Given this list of marker genes TMEM41A, METTL2B, FAM120A, TUBGCP5, SETD9, BAG5, GART, BCOR, SOS1 (SOS Ras/Rac guanine nucleotide exchange factor 1), STRADB, PLXNC1, RGPD4-AS1, TLR2, POGLUT2 (protein O-glucosyltransferase 2), PBK, GAPDHP62, PARP9, LAP3, UTP18, TAF9B, SPTLC2, IQCC, VAPA, WDR7, NBPF10, LONRF2, CD1A, RSL1D1, YTHDF2, SYNE2, LAPTM4B, SLC25A43, HIKESHI, INIP, NAP1L3, FAM169A, CXCR2, NET1, TMEM126A (transmembrane protein 126A, NCBI Gene Id 84233), POU1F1, ZNF41, ALKBH8, PIGP, SH3BGRL, RUNX1T1, CREB3L2, KMO, MAD2L1, SERTAD2, LINC01792, GFOD3P, ABCE1, TFB2M, DDX10 (NCBI Gene Id 1662), FBXL3, PIK3AP1, KPTN, EDRF1, CDCA7, HSD17B12, ITGAV, TRIM3, EARS2, DDX31, IDNK, DUSP5P1, PRKD3, DIPK2A, LONRF3, NAP1L5, DTX4, TCL6, TVP23B, WDR86-AS1, BCS1L, PRKAR2B, ARHGAP42, LINC00927, SFXN1, CAMK2D, LY86, BRK1, LTA4H, RIC1, PRNT, HLA-DRB4, EGR3, CAPRIN1, ZBTB24, ARHGAP15, DAP3, MED10, KLHL14, MBLAC1, PITPNB, OSGIN1, ABCD3, COTL1, MAK16, ZNF514, DYRK2, POP5, FBXW8, MFSD6, ZMYND8, ZNF766, FNBP1L, TNFRSF21, TMEM183A, SLC22A18, ZBTB21, HTATSF1, GOLT1B, HERC2, RIGI, WEE1, GTF2I, HDAC4, TIMELESS, SNX22, FYCO1, CLLU1, KCNQ5, TMEM11, IDI2, DHX33, MOSPD2, TMEM218, CENPE, ZFHX3, GPHB5, GSPT2, EEF1G, GNG2, TRAPPC2, PIGK, B4GALNT2, FOCAD, INTS7, GLUD1, YBEY, MACROD2, BIRC2 (baculoviral IAP repeat containing 2), CCNT2, GFUS, RSU1, PPTC7, FCHSD2, COX5A, SMIM13, SLC25A37, IL1RAP, ZNF664, NAALADL2, BACH1, BRINP3, JARID2, TMEM44, LST1, SANBR, TAPT1-AS1 (TAPT1 antisense RNA 1 (head to head)), ANKRD36C, THAP12, PIGY, LINC00334, OASL, GRK4, RPS6KC1, UST, ZNF383, DNAJC3, CMPK1, C17orf58, NREP, OR9A1P, SOD1, BTBD3, MATN2, MRPL45, HS3ST3B1, NRIP3, TMEM237, ZNF527, KBTBD11, BCL2L13, RAPGEFL1, MRPL44, UROS, PLSCR1, DHFR, ZDBF2, E2F8, B4GALT5, MAGEH1, TMEM184C, MRLN, here is a description of the gene set: Tumor growth is associated with a profound alteration of myelopoiesis, leading to recruitment of immunosuppressive cells known as myeloid-derived suppressor cells (MDSCs). Analyzing the cytokines affecting myelo-monocytic differentiation produced by various experimental tumors, we found that GM-CSF, G-CSF, and IL-6 allowed a rapid generation of MDSCs from precursors present in mouse and human bone marrow (BM). BM-MDSCs induced by GM-CSF+IL-6 possessed the highest tolerogenic activity, as revealed by the ability to impair the priming of IFN- -producing CD8+ T cells upon in vivo adoptive transfer. Moreover, adoptive transfer of syngeneic, GM-CSF+IL-6-conditioned MDSCs to diabetic mice transplanted with allogeneic pancreatic islets resulted in long term acceptance of the allograft and correction of the diabetic status. Cytokines inducing MDSCs acted on a common molecular pathway. Immunoregulatory activity of both tumor-induced and BM-derived MDSCs was entirely dependent on C/EBP transcription factor, a key component of the emergency myelopoiesis triggered by stress and inflammation. Adoptive transfer of tumor antigen-specific CD8+ T lymphocytes resulted in therapy of established tumors only in mice lacking C/EBP in myeloid compartment. These data unveil another link between inflammation and cancer and identify a novel molecular target to control tumor-induced immune suppression. We used gene expression analysis to identify those factors, secreted by tumor-infiltrating MDSC, which could drive emathopoiesis. Moreover we compare gene expression profile of tumor-induced MDSC, obtained from either the spleen and the tumor infiltrate of tumor bearing mice, and in vitro bone marrow-derived MDSC. Genes down-regulated in CD11b+ cells from spleen of BALB/c mice bearing C26GM colon carcinoma versus CD11b+ cells from tumors of BALB/c mice bearing 4T1 mammary carcinoma. species: Homo sapiens Human Gene Set: GSE21927_SPLENIC_C26GM_TUMOROUS_VS_4T1_TUMOR_MONOCYTES_DN from publication Marigo I, Bosio E, Solito S, Mesa C, Fernandez A, Dolcetti L, Ugel S, Sonda N, Bicciato S, Falisi E, Calabrese F, Basso G, Zanovello P, Cozzi E, Mandruzzato S, Bronte V (PMID 20605485)